The following is a description of a gene set: species: Mus musculus Enables the transfer of organic anions from one side of a membrane to the other. Organic anions are atoms or small molecules with a negative charge which contain carbon in covalent linkage. Mouse Gene Set: GOMF_ORGANIC_ANION_TRANSMEMBRANE_TRANSPORTER_ACTIVITY, and this is the list of marker genes: Slc25a19, Mpc2, Slc16a1, Slc44a4, Slc25a5, Slc39a10, Slc22a8, Nherf1, Slc2a1, Slc13a2, Slc25a2, Slc7a10, Slc16a7, Slc39a4, Best2, Slc4a7, Abcg2, Ctns, Mfsd10, Grik5, Slc25a11, Slc6a20b (NCBI Gene Id 22599), Slc10a1, Pdpn, Slc25a25, Slc27a6, Slco1c1, Slc25a38, Slco6d1, Slc7a3 (NCBI Gene Id 11989), Slc7a9, Slc16a12, Grin2a, Grin2c, Slc7a11, Slc6a7, Slc6a15, Slc1a4, Slc25a24, Abcd1, Slc15a4, Slc37a1, Slc7a1, Slc10a5, Mfsd12, Slc6a1, Slc19a1, Grin3b, Slc33a1, Slc23a2, Slc1a3, Fabp1, Slc26a5, Slc19a3, Slc22a29, Slc25a54 (solute carrier family 25, member 54), Grid1, Slc16a6, Slc23a1 (solute carrier family 23 (nucleobase transporters), member 1), Slc32a1, Slc47a1, Slc25a17, Slc22a2, Slc2a3, Slc35b1, Slc35d2, Slc4a10, Slc22a30, Slc1a6, Slc6a9, Slc4a1, Slc25a10, Slc5a8, Slc16a13, Slc26a1, Slco2a1, Abcc1, Slc52a3, Slc52a2, Slc22a13, Slc25a41, Slco1a7, Slc39a8, Slc16a5, Abcd4, Nat3, Slc47a2, Cd36, Slc35d1, Slc22a19, Slc25a22, Slc22a3 (solute carrier family 22 (organic cation transporter), member 3), Slc6a20a, Asic3, Ceacam2, Grik3, Slc22a18, Slc46a1, Slc35d3, Slc13a5, Slco2b1 (solute carrier organic anion transporter family, member 2b1), Slc6a13, Slc38a9, Fabp2, Slc26a4, Slc17a5, Cftr, Slc26a8 (solute carrier family 26, member 8), Best1, Slc39a5, Slc10a3, Slc35b2, Slc51a, Slc36a3, Slc10a6, Slc4a3, Slc25a51, Slc7a2, Fabp5, Sfxn3, Grin2b, Slc25a31, Slc38a6, Fabp3, Slc27a1, Slc38a10 (NCBI Gene Id 72055), Slc66a1, Slc25a23, Slco4a1, Grin2d, Abcc2, Grik4, Slc51b, Tmem241, Slc22a7, Abcc4, Slco1a8, Slc2a8, Slc25a42, Grin3a, Slc26a2, Gria2, Slc22a27, Slc43a3 (NCBI Gene Id 58207), Slc16a10, Slc26a6, Slc22a26 (NCBI Gene Id 236149), Slco1a4, Slc1a1, Slco6c1, Slc25a26, Slc22a20, Slc38a5, Ank, Slc3a2, Slco3a1, Slc25a13, Slc7a8, Slc10a4, Slc7a5, Slc26a9, Slc25a12, Slc7a13, Slc1a2, Abcd3, Lrrc8a, Slc27a4, Slco1a1, Gria1, Slc4a8, Slco1a6, Slc1a7, Slc35b3, Slc38a11, Slc10a4-ps, Slc7a15, Slc26a7, Slc26a10, Grik2, Slc7a6, Slc25a44, Slc35a1, Slc16a4, Slc7a4, Slc7a14, Gja1, Slc25a4, Slc4a4, Slco1b2, Slc38a4 (solute carrier family 38, member 4), Abcd2, Slc39a14, Slco4c1, Abcb1b, Abcc5 (NCBI Gene Id 78340), Abcb1a, Slco1a5, Slc27a5, Slc4a5, Sfxn1, Slc22a1 (NCBI Gene Id 20517), Slc6a6, Slc17a9, Slc4a9, Slc13a3, Panx1, Mfsd2a, Slc4a11, Slc16a14, Slc16a11, Slc36a2, Slc17a3, Sfxn5, Slc17a6, Slc26a11, Slc25a47, Slc6a5, Slc2a2, Slc38a8, Rtbdn, Slc5a12, Slc39a12, Slc6a14, Gria3, Ucp2, Slc25a21 (NCBI Gene Id 217593), Slc7a7, Slc43a1, Slc17a7, Slc25a39, Slc37a2, Slc38a7, Slc4a2, Mpc1, Slc5a6, Slc36a1 (solute carrier family 36 (proton/amino acid symporter), member 1), Slc6a12, Slc1a5, Slco6b1, Abcb11, Slc25a29, Slc38a1, Slc10a2, Abcc3, Slc22a28, Slc25a18, Grik1, Slc10a7, Slco5a1, Slc46a2, Slc43a2, Slc25a16, Slc22a14, Slc16a8, Slc25a1, Slc25a40, Grid2, Slc7a12, Slc26a3, Grin1, Slc39a6, Slc37a4, Slc17a8, Slc35b4, Slc16a3, Slc22a6, Tspo2, Slc38a2, Fabp4, Slc2a10, Slc25a32, Slc27a2, Slc16a9, Slc6a8, Abcg3, Slc25a15, Ceacam1, Gria4 (glutamate receptor, ionotropic, AMPA4 (alpha 4)), Slc36a4, Slc6a11, Slc38a3